The following is a description of a gene set: studied in species Homo sapiens Any process that activates or increases the frequency, rate or extent of the acrosome reaction. Human Gene Set: GOBP_POSITIVE_REGULATION_OF_ACROSOME_REACTION, and this is the list of marker genes: GLRA1, CCDC87, PLCB1, IQCF1, CACNA1H, ZP3, PRSS37, PLB1, PLA2G10, ZP4, FAM170B